The following is a description of a gene set: Type I hemidesmosome assembly Human Gene Set: REACTOME_TYPE_I_HEMIDESMOSOME_ASSEMBLY species: Homo sapiens, and this is the list of marker genes: LAMC2, LAMB3, ITGB4, KRT14, DST, CD151, ITGA6, COL17A1, KRT5, LAMA3, PLEC